The following is a description of a gene set: studied in species Homo sapiens Neighborhood of MYL2 Human Gene Set: GNF2_MYL2 Neighborhood of MYL2 myosin, light chain 2, regulatory, cardiac, slow in the GNF2 expression compendium, and this is the list of marker genes: TNNI3, MYL3, TCAP, FLNC, MYBPC3, CKMT2, PTP4A3, HRC, FABP3, SLC25A4, TNNT2, CSRP3, MYOZ2, HSPB7, ACTC1, TNNC1 (troponin C1, slow skeletal and cardiac type), POPDC2, CASQ2, COX7A1, DES, MB, MYH6 (NCBI Gene Id 4624), SYNPO2L, PGAM2, MYL2, RPL3L, NPPA, COX6A2, ACTN2, MYH7, NMRK2, MYL7